Given this list of marker genes ZNF174, ZG16, ZNF467, UPK3A (uroplakin 3A), VNN2, THBD, ACIN1, ASL, LRIG1, ERICH1, C2orf72 (NCBI Gene Id 257407), RGP1, LINC00302, ANXA10, CDC25B, FCHO1, GRHPR, HOXB13, B3GALT4, MAPK3 (mitogen-activated protein kinase 3), KAT7, CPB1, STS, DGCR2, PER1, ARHGEF11, PLXNA3, ACSBG1 (acyl-CoA synthetase bubblegum family member 1), PROZ, SLC25A13, GADD45A, NCKIPSD, MICA, PCMTD2, ZBTB25, DOP1B, TACR3, TRIM3, SLC25A42, PPARD, RBM38, CD300C, PLXNA2, TAOK3, ZNF8, FOXO4, CORO2B, ST3GAL1, STARD5, TRAF3IP2, ITGA2B, COL21A1, HHEX, PIM2, USP19, RDH5, MYCNOS, PAX6, TBX1 (T-box transcription factor 1), CYP2D6, CRP, AIP, FCMR, CXCR4, H2BC6, TREX1, ACAA1, WWOX, EN2, CYP3A5, FAM3A, HSF2BP, KLKB1, ZBTB7B, CYBB, ARID4B, SULT4A1, UBA7, TNFRSF13B, NMBR, HOXA11, MVD, AQP5, CDH2, ZKSCAN5, DGKA, CIZ1, ZC3H7B, LFNG, CIT, CDC42BPA, FLOT2, SORBS3, EDN2, ABCC10, PLA2G4C, MAPK11, MYO6, CA11, PIM1, PXDC1, CTSW, EXTL3, ACVR2B, JUNB, SHOX, HEXIM1, IMPDH1, CEACAM7, MAP3K9, PPP2R5D, CDH22, MEGF6 (multiple EGF like domains 6), KRT76, TXNIP, GATAD1, TYR, SIGLEC6, DNAJB1, ASIC2, MRNIP, PYGM, H4C2, PIK3IP1, CADPS, HSD3B2, PLIN1, BBLN, TBC1D9B, SPP2, DHCR7, TPM2, NEFL, DCC, CPZ, SC5D, ITSN1, FXYD3, TSN, FAM50A, PPEF2, OCRL, LPAR2, DIO2, BTBD2, PHKG2, MRC1, TRIB2, SIRPA, ARSL, SIT1, SERPINF1, SERPINB7, ZNF101, NME3, INSL4 (NCBI Gene Id 3641), CXCR6, P2RX5, KRTAP5-9, RPL14, S1PR4, CLDN9, NR5A1, IGLV3-25, ULK2, STX11, FLRT1, PCDH7 (NCBI Gene Id 90855), NXPH4, RAB6B (RAB6B, member RAS oncogene family), AQP2, NEURL1, PHLDA2, ESR1, BDH1, GLYAT, TANC2, XDH, NPY2R, MCF2L, PTH2R, NALF1, PIAS3, RAB31, MT2A, SLCO2B1, PITX2, CTSA, PPM1H, MYL2, SARDH, PDCL, GUCA2A, HOXD8, RHOB (NCBI Gene Id 388), KAT2A, TBX19, KLF5, here is a description of the gene set: from publication Constantinides MG, Picard D, Savage AK, Bendelac A (PMID 21632718) Genes down-regulated in Va24- NKT cells: naïve versus activated. Human Gene Set: GSE28726_NAIVE_VS_ACTIVATED_VA24NEG_NKTCELL_DN Microarray analysis was performed to determine the transcriptional profiles of NKT, CD1d-aGC+ Va24-, and CD4 T cells. studied in species Homo sapiens